Given this list of marker genes MATR3, NLGN4Y, RAN, LUC7L2, CATSPERE, C9orf57, LSM10, XRN2, QKI, ATP8A1, ZNF280B, ZMYND11, FBXO8, CTNNA3, ZFAND6, FASTKD3, SETD7, MCTP1, PCMTD1, FRYL, MOXD1, BEND6, EYA3, CSNK1G3, AZIN1, SMARCA2, FMC1-LUC7L2, ZNHIT6, GNB4 (G protein subunit beta 4), GRM8, SNX12, EPPIN-WFDC6, UBASH3B, SS18L1, MOSPD2, CPSF6, LAMC1, CAAP1, TBL1XR1, NXPE3, DMRTA1, NQO1, ZBTB1, FAM114A1, CHD4, GPATCH2, SHROOM3, ZKSCAN3, METAP1D, DYNC1LI1, PLA2G4D, DNAJC21, TNFRSF11B, LRBA, MINPP1, CALCR, CHML, ITPK1, ALG9, C18orf21, STS, ZBTB20, KAT7, YWHAG, CXCL12, MEGF9 (multiple EGF like domains 9), HTR2C, MED23, GPCPD1, LIFR, VAC14, NALCN, PLA2R1, ACVR2B, CERK, HMGCLL1, TWSG1, LRRC58, GABRG2, RPAP3, DEK, LYSET, FAM216B, VEZT, ADAR, AXIN2, SPO11, PIK3R1, PPT1, ARSJ, FAM114A2, ADGRA3, TMF1, PCSK1N, here is a description of the gene set: from publication Chen Y, Wang X (PMID 31504780) studied in species Homo sapiens Human Gene Set: MIR5100 Genes predicted to be targets of miRBase v22 microRNA hsa-miR-5100 in miRDB v6.0 with MirTarget v4 prediction scores > 80 (high confidence targets).